The following is a description of a gene set: species: Homo sapiens A G protein-coupled receptor signaling pathway initiated by amylin binding to its receptor on the surface of a target cell, and ending with the regulation of a downstream cellular process. Human Gene Set: GOBP_AMYLIN_RECEPTOR_SIGNALING_PATHWAY, and this is the list of marker genes: CALCR, RAMP1, CALCA, RAMP3, IAPP, RAMP2